The following is a description of a gene set: from publication Chen Y, Wang X (PMID 31504780) species: Mus musculus Mouse Gene Set: MIR_30D_3P Genes predicted to be targets of miRBase v22 microRNA mmu_miR_30d_3p in miRDB v6.0 with MirTarget v4 prediction scores > 80 (high confidence targets)., and this is the list of marker genes: Tirap, Col4a5, Dennd4c, Lrrtm2, Cdk17, Etfrf1, Dgkk, Hace1, Atxn3, Prkaa2, Acyp2 (NCBI Gene Id 75572), Fndc5, Tab3, Mindy2, Cdc73, Nfkb1, Rab11fip2, Trim34a, Papss2, Il17re, Zfp980, Lcorl, Zfp612, Zfp958, Qtrt2, Capn6, Lancl3, Lhfpl3, Gne, Cebpzos, Ctag2, Hcfc1, Dennd1b, Smu1 (NCBI Gene Id 80521), Kcna2, Zc3h14, Ptpn3, Zfp84, Ttpal, Itga4, Ildr2, Hsf3, Relt, Ube2g1, Ccdc184, Camsap1, Myo5a, Sgms2, Ep300 (NCBI Gene Id 328572), Kmt2a, Zfp827, Trhr, Zeb2, Acad11, Nr1d2, Zbtb41, Hpgd, Zbtb18, Tob1, Nr2c2, Kcnb1, Pik3c2a, Dnajb4, Thoc2, 9530002B09Rik, Donson (NCBI Gene Id 68649), Cdadc1, Hhip, Prkacb, Ermn, Atp8a1, Six4, Eogt, Sun2, Ap4e1, Htr2a, Ube2f, Sh3glb1, Pde5a, Ccdc80, Suco, Fam13c, Npy2r, Zfp558, Ccn3, Hcls1, Ppp6r2, 4930579G24Rik, Pclo, Arf6, Nufip2, Slc25a24, Mug2, Rex2, Chpt1 (choline phosphotransferase 1), Sh3bgrl2, Gpr158 (NCBI Gene Id 241265), Rpap3, Igf1, Pi4k2b, Adamts9, Mbd1, Dhx9, Csnk1e, Chml, Nol4, Slc25a33, Naa15, Pdk4, Med12l, Ipo5, Slc12a6, Rmi2, Ryr3, Paip2, Ss18, Cyth3, Tead1, Emc4 (NCBI Gene Id 68032), Dock11, B4galt6, Rgs7, Col12a1, Mnt, Zfp600, Hmgcll1, Acsm5, Ptar1, Stox2 (storkhead box 2), Meox2, Adamts5, Cep162, Tspyl1 (NCBI Gene Id 22110), Nap1l2, Antxr2, Cnpy2, Fam241a, Tet2, Mbnl3, Cadm2, Abhd5, Serpine1, Tbx4, Sfmbt2, Sh3gl3, Trem1, Slitrk3, Ptpn21, Hadh, Magea2, Cpsf2 (cleavage and polyadenylation specific factor 2), Sema3d, Pno1, Smim11, Psd3, Hira, Rala, Rela, Mcm8, Arx, Hmga2, Tmem140, Magt1, Lifr, Zfp937, Robo1, Syne1, Fat1, Stau1, Serpinb8, Rtl3, Nabp1, Ypel5, Ccpg1, Pank2, Fut9, Macir, 2610528J11Rik, Traf3ip2, Nup153, Ap1g1, Tnfaip1, Ttr, Bmp5, Zkscan4, Npffr2, Phip (pleckstrin homology domain interacting protein), Ppt1, Tmem47 (transmembrane protein 47), Aasdhppt, Slc24a2, Ubr5, Ror1, Cbfb, 5730480H06Rik, Csnk1g3, Luc7l3, Ar, Msr1, Rarb, Shprh, D630039A03Rik, Bccip, Ralgps1, Cacybp, Stim2, Themis, Slitrk2, Rgs7bp, Scai, Dhfr, Col1a2 (collagen, type I, alpha 2), Pdss2, Ninl (NCBI Gene Id 78177), Aqp4, Egr1, Gnl1, Tril, Cdh6, Tnrc6b, Ankrd26, Kpnb1, Rock2 (Rho-associated coiled-coil containing protein kinase 2), Zfhx3, Apc, Arid4a, Ube2j1, Anapc10 (anaphase promoting complex subunit 10), Cdk14, Zfp81, Ralb, Bche, Ccnjl, Il1rn, Usp1, Mecp2, Erap1, Trim33, Tigd4, Wrn, Tshr, Tfrc, Fchsd2, Prkd3